Given this list of marker genes ENSG00000270159, RNA5SP433, COX4I1, GAS8-AS1, MIR5093, CPNE7, LINC02181, VPS9D1, CBFA2T3, ANKRD11, APRT, CICP25, ZNF778-DT, IRF8, SLC7A5, LINC00304, ZCCHC14-DT, GALNS (galactosamine (N-acetyl)-6-sulfatase), DEF8, DNAAF1, TAF1C, LINC00917, C16orf95, SPATA2L, RNF166, MTHFSD, FAM157C, ENSG00000261697, KLHDC4, CRISPLD2 (NCBI Gene Id 83716), RNU6-430P, FOXF1, AFG3L1P, SNAI3, KLHL36, ZC3H18, PIEZO1-AS1, TUBB3, ZNF469, PRDM7, RNU1-103P, MBTPS1, FOXC2-AS1, CIBAR2, WFDC1, TCF25, LINC01082, CMPK1P2, CENPBD1P, ENSG00000260466, KCNG4 (potassium voltage-gated channel modifier subfamily G member 4), CHMP1A, JPH3, PIEZO1, TUBB8P7, MIR5189, MC1R, CTU2, RPL7AP63, RPL10AP12, ENSG00000250685, C16orf95-DT, LINC02166, GSE1, IL17C, ENSG00000261327, ENSG00000261118, MIR6775, SNAI3-AS1, URAHP, ENSG00000300780, FBXO31, GINS2, LINC02138, COX6CP16, FOXC2, ACSF3, MAP1LC3B, LINC02139, MEAK7, CA5A, MIR6774, USP10, ENSG00000297285, ADAD2, LINC02176, MIR1910, SLC22A31, CDH15, ZNF778, TRAPPC2L, MIR4722, GAS8, ATP2C2-AS1, RN7SL381P, ENSG00000259881, ZCCHC14, LINC02188, DBNDD1, ENSG00000299948, ZNF276, LINC02132, ENSG00000302808, RNU6-355P, ZFPM1, MBTPS1-DT, ENSG00000260279 (novel transcript, antisense to ANKRD11), ENSG00000295471, COTL1, KIAA0513, SPATA33, ENSG00000226180, DPEP1, HSALR1, LINC00311, ZDHHC7, LINC02135, LINC02189, EMC8, FLJ30679 (NCBI Gene Id 146512), ATP2C2, SPG7, RPL13, LINC01081, CDK10, SPIRE2, HSDL1, BANP, SNORD68, PABPN1L, ENSG00000300469, ENSG00000269935, C16orf74, LINC02182, ENSG00000305162, FOXL1, ZFPM1-AS1, CYBA, FANCA, VPS9D1-AS1, FENDRR, MVD, CDT1, ENSG00000288715, ENSG00000261095, here is a description of the gene set: studied in species Homo sapiens Human Gene Set: chr16q24